The following is a description of a gene set: Human Gene Set: HP_MYOFIBRILLAR_MYOPATHY Myofibrillar myopathy Myofibrillar structural changes characterized by abnormal intracellular accumulation of the intermediate filament desmin and other proteins. studied in species Homo sapiens, and this is the list of marker genes: LDB3, FHL1 (NCBI Gene Id 2273), BAG3, FLNC, ACTA1, TTN, DNAJB6, KLHL40, MYOT, AKT1